The following is a description of a gene set: studied in species Homo sapiens Human Gene Set: HP_IMPAIRED_EXECUTIVE_FUNCTIONING A disturbance of executive functioning, which is broadly defined as the set of abilities that allow for the planning, executing, monitoring, and self-correcting of goal-directed behavior while inhibiting task-irrelevant behavior. At least some degree of executive skill is needed to complete most cognitive tasks, and deficits in executive abilities are central to many clinical conditions, including fronto-temporal dementia. Impaired executive functioning, and this is the list of marker genes: NPTX1, MPV17, VPS13D, SPTLC1, PDGFB, CSF1R, FAR1, SPG7, APTX (aprataxin), CYLD, MMACHC (NCBI Gene Id 25974)